Given this list of marker genes SF3B1, SNRPGP15, PRPF40B, SNRNP70, LUC7L, SF3A1, SF3A2, DDX42, SNRPN, LUC7L3, PRPF39, U2AF2, LUC7L2, SNRPG, PRPF40A, SNRPB, SNRPC, LSM7, here is a description of the gene set: species: Homo sapiens A spliceosomal complex that is formed by association of the 5' splice site and the branch point sequence with specific snRNPs. The prespliceosome includes many proteins in addition to those found in the bound snRNPs. Commitment to a given pair of 5' and 3' splice sites occurs at the time of prespliceosome formation. Prespliceosome complexes are not active for splicing, but are instead an early step in the assembly of a spliceosomal complex. Human Gene Set: GOCC_PRESPLICEOSOME